The following is a description of a gene set: species: Mus musculus This event has been computationally inferred from an event that has been demonstrated in another species.<p>The inference is based on the homology mapping from PANTHER. Briefly, reactions for which all involved PhysicalEntities (in input, output and catalyst) have a mapped orthologue/paralogue (for complexes at least 75% of components must have a mapping) are inferred to the other species. part of: Transport of small molecules electronically inferred by orthology from the curated human pathway Reactome Pathway: Miscellaneous transport and binding events, and this is the list of marker genes: Tusc3, Nipal4, Mrs2, Add1, Rhbg, Csn1s1, Rhcg, Azgp1, Csn3, Ctns, Pip, Slc66a1, Nipal1, Lrrc8c, Dmtn, Nipal3